The following is a description of a gene set: Genes containing one or more binding sites for (Foxn1) in their promoter regions (TSS -1000,+100 bp) as identified by GTRD version 20.06 ChIP-seq harmonization. from publication Yevshin I, Sharipov R, Kolmykov S, Kondrakhin Y, Kolpakov F (PMID 30445619) Mouse Gene Set: FOXN1_TARGET_GENES species: Mus musculus, and this is the list of marker genes: Lysmd1, Ablim1, Id4, Myrf, Ppp5c, Pkig, Atp6v0d1, Atg4c, Zfp706, Gns (NCBI Gene Id 97675), Amotl1, Foxj3, 4930528J11Rik, Gm9857, Trpm7, Tox4, Bhlhe40, Vmac, Pcbp1, Unc13a, Ulk2, Sav1, Atad2b, Fam193a, Tob1, Retreg1, N4bp2l2, 4933405D12Rik, Mafb, Pithd1, Rnpc3, Pard3, Gm14207, 4930579D09Rik, Smap1, Atp11a, Tcf4, Crk, Rnf6, Rbbp8, Ess2, Isy1, Vav3, Gprin1, Ccdc85c, Scrt1, Scaf11 (NCBI Gene Id 72193), Glt28d2 (NCBI Gene Id 320302), Apobec3, Dsc3, Ptp4a2, AI597479, 1700041I07Rik, Rexo1, Fhip1b, Dst, Preb, Fxr1, Washc4, Prn, Mtmr6, Rpl3 (NCBI Gene Id 27367), Zfp341, Gtdc1, Gbp10, Prss16, Cdipt, H3f3b, Slc44a1, Chordc1, Snord43, Ift43, Secisbp2l (NCBI Gene Id 99005), Mmgt1, Mtss2, Brpf3, Dnajc13, Cdh4, Actn3, Trpc4ap, Raver2, Nup93, Chd2, Acad11, Anapc11, Morf4l1, Diaph1, Mrrf, Virma, Rsf1, Mir7648, Zmiz2 (NCBI Gene Id 97766), Ppp1cb, Gm20732, Klhl11, Sec23a (NCBI Gene Id 217612), Sez6, Trarg1, Henmt1, Tpt1, Phf3, Tmem87b, Nmbr, Mettl18, Retreg2, Crip2, 2810407A14Rik, Agk, Nme1 (NCBI Gene Id 18102), Sirt1, Exoc2, Epo, Birc2, Akap10, Gmfb, Fra10ac1, B130034C11Rik, Coq9, Fam50b, Ciapin1, Pknox1, Aamdc, Dynlt3, Lhfpl7, Ing3, 1110059E24Rik, Sema6a, Scnm1, Cacng2, Odc1, Gnb2, Wdr70, Dop1a, Rfwd3, Arfgef2, Garem1, Efcab2, Usp12, Zswim6, Anapc1, Ubc, Gm16675 (predicted gene, 16675), Cdc42ep3, Cep120, Ercc6l2, Eaf2, Gm38250, Eps8, Enc1, Kdm2a, Aimp2, Arid1a, Mrpl15, Kmt2b, Edar, Gnpda2, Wfikkn2, Aasdh, Ark2c, Nos1ap (nitric oxide synthase 1 (neuronal) adaptor protein), Ctnnb1, Cdk8, Iqcb1, Cep57, Tbata, Smg7, Rnf7, Taco1, Casp14, Rab2b, Ppp1r2, Uchl5, 5031439G07Rik, Slc39a1, Cox5a, Txndc9, Adgrl3, Tex261, Ube2d2a, Slc38a2, Tgfbrap1, Atxn7l1, Gm5447, Nr4a2, Cnot6, Frg2f1, Alkbh3, Mtf2, Gbp9, Tsn, Ift46, Galnt11, Lemd2, Lsm12, Naprt, Jup, Usp4, 1700108F19Rik, Slc12a2, Scg2, Gm22618, Srxn1, Bhlhe41, Secisbp2, Bsg, Zfp382, Glo1, Mtmr3, Ncor2, Actn4, Srsf1, Atf6, Taf4, Cuedc1, Sc5d, Ppargc1a, Hes6, Man1b1 (NCBI Gene Id 277406), Atp5mc3, 4921531C22Rik, Cnppd1, Alpk1, Iqank1, Ss18l1, Msmo1, Ache, Mdh1b, Cct8, Iscu (iron-sulfur cluster assembly enzyme), Gm14110, Map2k7, Nisch, Sdad1, Mcm10, Crebzf, E130116L18Rik, Bag5, Cdkn2aip, Etnk1 (NCBI Gene Id 97308), Alyref, 2810408A11Rik (RIKEN cDNA 2810408A11 gene), Ndufa11, Mcc, Gm15420, Rph3a, Cltc, Nudt16, Pgp, Agap3, Hnrnpa0, Stx11, Ube3c, Mir100hg (Mir100 Mirlet7a-2 Mir125b-1 cluster host gene), Btbd6, Pex7, 4930539J05Rik, Magi1, Dpy19l3, Arrdc3, 1810037I17Rik, Gm10472, Rbck1, Saal1, Mrpl48, Get4, Cdiptos, Dstyk, Glud1, Tbx3os1, Barhl1, Fam76b, Nipsnap2, 1600020E01Rik, Erbin, Eif4a2, Slc16a9, Jun, Sptlc1, Gm23130, Coa8, Rps12 (ribosomal protein S12), Abhd17b, Mybpc2, Zfp740, Tfap4, Tbl1x, Cdh11, Shld2, Urb2, Cxxc4, Tex14, Tpk1, Zmynd11, 4933439K11Rik, Gtf2b, Prnp, Scp2, Sik3, Ss18l2 (SS18, nBAF chromatin remodeling complex subunit like 2), Sik1, Cebpb, Mir125b-1, Syncrip, Dctn4, Eif5b, Odad4, Arfip1, Yap1, Sinhcaf, Mtcl1, Vta1, Ccdc60, Gm26766, Mtln, Irf2, 1700023H06Rik, Ndufa7, Rps10, Rheb, Csde1 (cold shock domain containing E1, RNA binding), Brca2, Bola3, Fkbp9, Polr1h, Rtraf, Adgrb3, Cyb5r4, Nfix, Pdzd2, Rps28, Snrpd1, Ccdc34, 4930519P11Rik, Bcl3, Cops8, Agpat3, Gtf2a1, Yipf6, Glra1, Lonp1, Mapk8ip2, Gucy1a2, Tcf12, Nudt5, Susd6, Thumpd2, Neurl4, Socs1, Fastkd2 (FAST kinase domains 2), Ino80dos, Mir203, Ufl1, Ndufaf4, Tcf3, Bnip3l, Gm35439, Cic, Washc1, 2410022M11Rik, Taf5l, Junos, Slc39a13, Zmym5, Eif4b, Zdhhc24, Xpot (NCBI Gene Id 97647), Pms2, Fam83h, Dlgap4 (NCBI Gene Id 98882), Hspb8, Fermt2, Osbpl10, 4933425M03Rik, Ccdc107, 4930405A21Rik (RIKEN cDNA 4930405A21 gene), Wdr41, Cacng3 (calcium channel, voltage-dependent, gamma subunit 3), Fam3c, Crbn, Tatdn2, Nudt9, Ap1g1, Mmut (methylmalonyl-Coenzyme A mutase), Polr1has (NCBI Gene Id 76416), Rev1, Eif4enif1, Ints10, Rbm18, Spaca6, 2310057M21Rik, Ro60, Cops4, Sart3, Bcl9l, Ap4e1, Gm826, Alg10b, Gm8066, Ube2d3, Altre, Cpne4, Rbm12b1, Scap, Mex3c, Mrpl39, Mir7b, Hivep2, Gm25794, Cnot11, Mir3569, Dsp (NCBI Gene Id 76767), Meis2 (NCBI Gene Id 319479), Firrm, Cdc123, Rnf44, Agap1, Psma7, Dcaf1, Gm4791, Mtmr10, Pten, Stag1, Rnf38, Ccnl1, H2ac19, Brd1, Setdb1, Nav3, Gm31651, Plgrkt, Nedd4 (neural precursor cell expressed, developmentally down-regulated 4), Tmem219, Gm9929, Gm4285, Nfyb, Spen, Litaf, Ftx, Mir375, Fgf9, Elmod2, Sema3c, Cep126, Ppp4r4, Bbs7, Sec31a, Plekhb1, Zfp667